Given this list of marker genes MTBP, KLHL32, ZNF382, ALDH6A1, TRAF3IP2-AS1, PYGB, RNF150, ZCWPW1, PRKAA1, PPP2R5C, TBC1D19 (NCBI Gene Id 55296), RBM28 (NCBI Gene Id 55131), FGFR1OP2, IGF2BP3, PAWR, CCBE1, SNHG7, MAP3K13, GOLGA3, UBXN2A, SIGIRR, S100PBP, ELP3 (elongator acetyltransferase complex subunit 3), ZNF205, GMNN, MRPL38, SNRPD3, KPNA1, PTCH1, USP54, PTP4A2, VAMP1, RCOR3, GNL3, MIER1, SLC39A11, GNL1, VWA5B2, YTHDC1, MYO9B, ARHGEF12, ECE2, EPHB1, POLE2, LINC01132, CYP51A1-AS1, UBE2Q1, EMC1, PANK1-AS1, CDKN3, NAV2, HOXC9, IRF9 (NCBI Gene Id 10379), LRCH3, GATA6-AS1, DDX55, PSMG3-AS1 (NCBI Gene Id 114796), YAP1, JMJD4, MIR548AW, TNPO2, GTF2B, RPL15, MAP3K8, ISG15, SGSM1, PIP5KL1, DBNL, MIR3677HG, FBXO27, MIR4674, AURKB, VPS25, RRM2, RAC1, TMEM14B (transmembrane protein 14B), TMEM255A, NUDT18, CEROX1, GPS2, NR2F6 (nuclear receptor subfamily 2 group F member 6), CLDN6, SLC39A8, DDN, GABARAP, CIDECP1, PSIP1, SMARCD2, KCNK5, CCDC171, SMAD6, RNU7-27P (RNA, U7 small nuclear 27 pseudogene), TRIM33, MIR3143, PDIK1L, TK1, SIX5, SEC22C, CEP250, RFC4, SLC25A23, KCNQ4, KAT6A, ARB2A, SLC39A6, HAUS8, SMARCE1, CCDC136, SARAF, CCDC174, OSR2 (odd-skipped related transciption factor 2), ZBTB1, NR4A3, TMEM68, CDC42EP4, PEAK1, STX18-AS1, PPP1R2, NOP56, FAM13B (NCBI Gene Id 51306), H4C8, TMCC2, GPR89A, ALG3, LAMP1, GFM1, CNN3, EIF3G, HOXC-AS1, RNU6-1039P, FBXW8, PNP, IRF5, POLR2B, SLC25A53, C19orf53, NUFIP2, TGFBR3, S100A2, TIAM1, SBDS, VTRNA1-2 (vault RNA 1-2), TRDMT1, CNN3-DT, EMC3-AS1, HUS1 (NCBI Gene Id 3364), RHOT1, MFN2, MAP3K5, SIK3, BRD2, SMG1P2 (NCBI Gene Id 440354), KCNK1, PROX1, HSP90AB1, DHX33, PREP, ANKRD24, BBS1, ENSG00000274248, NFE2L1, GNB2, INTS13 (NCBI Gene Id 55726), SEPTIN6, PRDM6, SRM, ALKBH3, AGO3 (NCBI Gene Id 79910), LEISA1, METTL15, CCDC192, ZFP64 (ZFP64 zinc finger protein), H2BC26 (NCBI Gene Id 128312), DDX39B, FAM131B, PANK1, SRGAP3, PSMD11, GALNT16-AS1, H2AC12, SQSTM1 (NCBI Gene Id 94002), SLCO5A1, USP21, MACO1, CCDC159, ZNF276, NBPF19, FAM83G, E2F2, QRSL1, PYM1, UBE2E1, MTFR2P2, RN7SL446P, RAB11FIP5, NEIL1, COQ4, BRPF1 (NCBI Gene Id 7862), ST3GAL3, GGA1, ZBTB4, H2BC12, STX16, SNORD55, UQCC6, LIN52, PSMG3, RPS29, EPB41L4A-AS1, EPS8L1, USP30 (NCBI Gene Id 84749), CNOT6, MIR646HG, ZNF569, HSDL2-AS1, GTF3C5, MDM2, ARID1A, FGD5-AS1, BRWD3, ALDH1A2, THAP7-AS1 (THAP7 antisense RNA 1), SEC14L1, EGR2, CUL2, GFM2, H3C1 (NCBI Gene Id 8350), MRPL39, SLC7A5P1, KLHL22 (kelch like family member 22), SNHG11 (NCBI Gene Id 128439), CRK, PPP2R3A, ZNF827, REV3L, SRCAP, COQ3, KBTBD4, SUGT1P4-STRA6LP-CCDC180, TOX4, NOC4L, AP3S2, ZNF433-AS1, WDR11, CHST15, TLE2, TFRC, TCF4, CDK11A, B4GAT1-DT, NCOR2, PPP6R1, DYNC2I2 (dynein 2 intermediate chain 2), GSTCD, CBX4, PREX2, SLC35E2B, MPHOSPH9, BCAN-AS2, NBPF25P (NBPF member 25, pseudogene), BMS1, ALG10B, ASCC1, RPL11, EXOSC3, PLBD2, NCAM1, H2BC18, ZNF581, CDC37, SNHG6, SUGT1P4, PSMD4, SAR1A, NOL8, PTOV1, CDK6, PRECSIT, MYG1, MIS12, SNORA13, NFE2L2, MIR4479, CDK19, KDM4A-AS1, PDXK, PRKG1, NOSIP, ARF6, HYCC1, FAM43A, RHCE, DNAJC3-DT, NFKB1, ELK4, ASPHD1, CITED2, SUMF1, SETDB2, RBBP5, MAX, KLHL18, ZNF383, MTRFR, ALG1, GFI1B, PRIM1, ENSG00000277020, SUDS3, OGFRL1, ARFGEF2, MRPS31, GDF5, GTF2IP12, RBPMS, TASOR, NICN1, EPOR, WDR47, PGM2L1, B4GALT1-AS1, EFNB2, CCT5, YARS1, TMEM101, MTG1, POLR2A, NEURL2, FAM98C, ADD1 (adducin 1), TSKU-AS1, SMAP2, TOP6BL, MIR4530 (microRNA 4530), RTEL1, GNAQ, RFX1, GNAI2, SF3A3, STARD13, CALM1, GCAT, ISLR2, SMARCC2, UBTF, DPH7, KIAA1958, GUSBP1, DMAP1, UBE2H-DT (UBE2H divergent transcript), LINC01664, BCAR3 (BCAR3 adaptor protein, NSP family member), SSBP1 (single stranded DNA binding protein 1), TOMM22-DT, DPP9, ST8SIA1 (ST8 alpha-N-acetyl-neuraminide alpha-2,8-sialyltransferase 1), SRSF6, WDTC1-DT, TRMT1, RPS15, FRMD4B, MIB2, TNNT1, STX16-NPEPL1, TMEM121B, SETD5, MIR615, PPM1H, SRSF7, DNAI4, VEGFA, ETV2, ZNF609, WDR11-DT, DNPH1, DDX51, EP300, MIR1273C, MAZ, SUPV3L1, NME2, REXO4 (REX4 homolog, 3'-5' exonuclease), ADAT2, UBC, LINC01775, ICA1L, ABCA3, THUMPD3-AS1, SLC25A37, CCDC33, FBXL16, DUS1L, DVL2, PRKCI, CNIH3, MRPL1, ISG20L2, NSFL1C, RNF24, TRIP6, KANSL1, YWHAZ, CCDC77, RGS5, PCCA-DT, DCAF1, CALR, DISC1, FOSL2, TENT5B, RNF43, BBS7, TMEM74B, NR3C2, USP22, RPS8, UNKL, SEC22B, ZNF213-AS1, HAP1, CSTF2T, CRCP, TRIM45, TNS1, CHEK1, APOM, CCNE2, CAB39L, ADAM15, UGGT2, TENM3-AS1, ENSG00000248161, AURKAIP1, BBS7-DT, GTF2A1, SAR1B, UBB, TSFM, CCDC144BP, RPS4X, SLBP, FAM53C, BSDC1, NDUFAF1, NDUFC1, ZNF629, PHF20, ARHGAP28, GIN1, MNAT1, KDSR, GLUD1 (NCBI Gene Id 2746), OTOP2, HES4 (NCBI Gene Id 57801), NRF1, HSPA14, INHA (NCBI Gene Id 3623), GIT1, UBE3B, GNAL, SNORD84, EIF4A2, STC2, MTMR9, C5orf15, MTHFD1L, MROH8, PAK1, COPS7B, AFMID, DICER1-AS1, KLHDC9, PRR3, MAP3K7, ARID5B, CKMT2-AS1, CTSA, PROX1-AS1, GATA6, ZIC2, LINC01275, NAGK, DPP8, CDC42SE1, PLCXD1, ZNF335, EDC4, RNPS1, NICOL1, JOSD1, ANKRD18B, TAB2, ZNF570, TTLL7, TMEM242-DT, NALT1, FIRRE, PTOV1-AS1, LRP6, CDC25C, SLC24A1, CD2AP-DT, DLL4, INTS14, VPS33A, BAG6, CYP51A1, YJU2, BACH1, WDR83, OAZ1, CSNK1D, H4C5, ERCC6L2, MTERF4, HIF1AN, UBE2H, PSTK, SPRED3, EIF3F, HEMK1, SLC2A4RG, MAML3, CPVL, BLOC1S1, DCP2, HEXA, CENPP, NKILA, SHTN1, PAFAH2, STAT3, ING1, TMEM167B, SPAG4, TSHZ2, DRAP1, NELFE, SNHG17, NOTCH2NLA, CCN1, B4GAT1, DISP3, CCDC106, PLCD3, MIDN (NCBI Gene Id 94034), TRUB2, JAK2, IRF1, RAD51, BANF1, PHIP, FASN, ZBED9-AS1 (NCBI Gene Id 121676925), ADD3 (NCBI Gene Id 121), SDC4, TACO1, ENPP3, AP1G1, KATNAL1, ZNF790, SSBP2, NAGPA, PRRC2A, RELL1, GEMIN8, STAT6, CELSR3, TMEM198B, BUB1B, SFSWAP, CDKAL1, DHX33-DT, NR2C2, SETD1A, COMMD5, BMS1P4, CHIT1, OPTN, MVK, NDUFA10, ATAD2B, SLFN12, IDI1, CD2AP, KCNB1, MYL6B-AS1, LAMTOR5, TGS1, C10orf88B, TNNT2 (troponin T2, cardiac type), HOXD3, HMG20A, PLEKHA8P1, DBR1, FZD1, THAP7, ENSG00000253270, SCAND3, NOTCH1, BABAM2, CFAP418, ZNF3, CYTH2, GRK6, CAPN7, METTL9, WWTR1, CDNF, FCHSD2, KAT6B, NECTIN1, C17orf58, UXT, ISOC1 (NCBI Gene Id 51015), MGAT4B, WDR83OS, MIIP, KDM5A, TMEM167B-DT, PPP1R3B, RPN2, TBPL1, BLOC1S6, AP4M1, BBX, SPAG5, CFAP410, TENM3, OLFM1, C11orf68, GRPEL2, OGDH, DNAJA1, LGI4, AJUBA-DT, GAMT, FRMD5 (NCBI Gene Id 84978), MIR3178, SCAMP4, MCOLN1, KCTD21, PHKA2, SUGCT (NCBI Gene Id 79783), STMN3 (stathmin 3), MKRN2, KRT19, PRRG2, NCDN, TSKU (NCBI Gene Id 25987), FAM234A, KIAA1586, DOK4, RBFOX2, SEPTIN7P14, LMF1, CZIB, MLEC, HEXIM1, SAMTOR, SYNCRIP, PNPLA3, SUPT7L, CAMK2N2, EFNA3, GLUD1P3, PTK7, ABCA17P, EIF2B3, NME1, TOMM22, MPI (mannose phosphate isomerase), B4GALT7, OSBPL1A, LRRC49, MARCHF4, VPS51, GUCD1, TARBP2, MYO3A, FAM133B, USH1G, STT3B, FZD2, ZCCHC24, NDUFS3, H1-10, OGT, TJP3, USP3, SLC35E2A, TCF3, STX18, SLC44A1 (solute carrier family 44 member 1), NKIRAS1, LAMTOR5-AS1, BCL7A, EIF2D, RPL18, COL6A4P1, GLI3, GBA1, SH3PXD2B, FRS3, MCPH1-AS1, MIR4734, HOXB3, VPS9D1, RRM1, ETS2, ZFP30, CCDC107, NPC1, RN7SL1, ZKSCAN3, KLC1 (kinesin light chain 1), RBM42, KDM1A, ZBTB25, SNORA16A, DCP1A, MICB, EIF4G2, PMEPA1, IGF1R, NFIA, MTF2, FTCD, PDE6D, TBX20 (T-box transcription factor 20), NME1-NME2, LINC01012, NDUFAF6, MCM8-AS1, CASP2, CACYBP, GIPC1, RTEL1-TNFRSF6B, SLC1A5, PBRM1, USP35, EFCAB7, ZNF181, DLK2, TSC22D4, MYL6, WDR26, ADGRE5, AJUBA, SNHG12, NUS1, SLC39A13, COX16, HOOK2, MRPL44, CCT6B, ADAT3 (adenosine deaminase tRNA specific 3), EXD2, FAM76A, BRPF3, EEF2, PGBD2, RIMKLB, ELP2, SMG1P3, ZNF585B, ZCCHC9, RNH1, ANAPC16, ENSG00000246308, TNRC6C, GGN, CDC73, COL1A1, DOC2A, MIR194-1, SRPRA, CRLS1, MIR1302-3, MRPL13, HTR3A (5-hydroxytryptamine receptor 3A), LINC00431, SREK1IP1, TLE3, EIF1AD, OBSL1, NELFA, TOP3B, CWC27, TRIP4, RTN4IP1, CADM4, NUTM2A-AS1, SPAG9, RGS9, ADD3-AS1, DRG2, FLT3LG, TAGLN2, PFKFB4, HOXC5, SIK2, RPL23AP82, OCEL1 (occludin/ELL domain containing 1), ARMH3, ZNF345, VCL, MRPS31P5, HNRNPUL1, ARID1B, ENSG00000232995, CCNL1, CPEB4, WEE2-AS1, RBKS, KPNB1-DT, SMG7-AS1 (SMG7 antisense RNA 1), MIR4634, ZFP36, ERAP1, TMEM14B-DT, ZCCHC4, FOXRED1, CENPU, UBE3C, PHF13, NBN, MIR548AL, SNAP47, XKR6, SEMA7A, PLXDC1, RAPGEF6, CHD1L, ENSG00000235480, BMS1P4-AGAP5, TPI1, EMC3, CABIN1, DNAJC6, TIMM44, NUF2, SPAG5-AS1, KIF20B, PPIP5K2, NAF1, ATPSCKMT, NECTIN1-DT, RBPMS-AS1, UTS2B, SRFBP1, PCLAF, GTF2A1-AS1, RAB2B, SEMA6D, DNAAF3, ZNF771, HEXA-AS1, VDAC1, PCCA, ENSG00000247416, CAST, EFHC1, EXTL3, CCDC97 (NCBI Gene Id 90324), ZSCAN16-AS1, PIH1D2, SLC39A3, PARL, NID2, ERCC6L2-AS1, AP2S1, HELLS, DNAJB12, RTTN, TRAF2, KIF9, FAM200A, SMG7, SUGT1P4-STRA6LP, CTNNB1, NSA2, SLC4A1AP, RPLP1, MPLKIP, GINS3, SEMA6A, H2AX, POLE4, MEPCE, RIN3, APTX, PTPN12, NCL, MXI1, PRICKLE2-AS3, DCLK1, GEMIN6, HDAC1, FANCD2, C11orf96, BLMH (bleomycin hydrolase), FSCN1, CDCA7, WLS, ZNF260, NKAPD1, PEX3, IRS4, KIAA0319L, SPHK2, ST13, JPX, RAD51-AS1, HIVEP3, MLLT10, CDK5RAP1, KCTD10, DERL2, ANO6, LINC02585, DDX39B-AS1, MED23, PDS5A, FBXW11, CZIB-DT, DICER1, RCOR1 (REST corepressor 1), WDR37, ZCCHC2, TARS2, MND1, SOX8, TSC1, ITGA7, INTS12, FAM13B-AS1, MIR5188, NOP16, ITGB3BP, TUFT1, ATP2B1, R3HCC1, IFT56, ST6GALNAC6, ATAD2, TM7SF3, SNX10-AS1, LINC01144, MCM7, TMEM242, NLRX1, MRPS31P4, EXOC3, FAM24B, FLNA, CDK1, VDAC2, GABPB2, HTR5A, H4C3, NOL12, RPSAP31, KPNB1, MCOLN3, CEBPG, here is a description of the gene set: studied in species Homo sapiens Human Gene Set: ZNF391_TARGET_GENES Genes containing one or more binding sites for (ZNF391) in their promoter regions (TSS -1000,+100 bp) as identified by GTRD version 20.06 ChIP-seq harmonization. from publication Yevshin I, Sharipov R, Kolmykov S, Kondrakhin Y, Kolpakov F (PMID 30445619)